Given this list of marker genes WARS2, KDM1A, ZEB2, FDXR, NARS1, PIGA, SLC2A1 (solute carrier family 2 member 1), NACC1, PSAT1, TMX2, STRADA, here is a description of the gene set: species: Homo sapiens Human Gene Set: HP_CEREBRAL_WHITE_MATTER_HYPOPLASIA Underdevelopment of the cerebral white matter. Cerebral white matter hypoplasia